The following is a description of a gene set: Dilated, glial-lined cavity in spinal cord. This cavity does not communicate with the central canal, and usually is between the dorsal columns unilaterally or bilaterally along the side of the cord. Human Gene Set: HP_SYRINGOMYELIA Syringomyelia species: Homo sapiens, and this is the list of marker genes: DDR2, NOTCH2, EXT2, RAI1, COG4, POLR1A (RNA polymerase I subunit A), SH2B1, DKK1, NOTCH3, IL11RA (NCBI Gene Id 3590), RBM8A, ACY1, CREBBP, CTNNB1 (NCBI Gene Id 1499), TBX6, EP300, FOXF1, SETD2, HNRNPK, SPARC, FBLN1, KDM1A, FBXO11, LEMD3, ABCA1, DDHD2, EXT1, HMGA2, CLP1, RUNX2, NRAS, NFIA, CCNQ